Given this list of marker genes Lmnb2, Nup54, Nup155, Tmem201, Nutf2-ps1 (NCBI Gene Id 18228), Tmem147, Plk1, Lmnb1, Nutf2, Ints13, Tor1aip2, Tor1aip1, Lmna, Osbpl8, Sumo1, here is a description of the gene set: Mouse Gene Set: GOBP_PROTEIN_LOCALIZATION_TO_NUCLEAR_ENVELOPE A process in which a protein is transported to, or maintained at, a location within a nuclear envelope. species: Mus musculus